The following is a description of a gene set: Neuroinflammation Human Gene Set: WP_NEUROINFLAMMATION species: Homo sapiens, and this is the list of marker genes: TLR4, RELA, MAPK14, NFKBIA, MT-CO1, NOS2, MAPK8, ASCC1, MTOR, JUN, CHUK, FOS, MT-CO2